The following is a description of a gene set: studied in species Mus musculus Any process that modulates the frequency, rate or extent of axon guidance. Mouse Gene Set: GOBP_REGULATION_OF_AXON_GUIDANCE, and this is the list of marker genes: Agrn, Pou4f2, Mycbp2, Slit2, Nova2, Tubb2b, Ythdf1, Tbr1, Robo3, Kif21a, Fezf2, Atoh7